The following is a description of a gene set: studied in species Mus musculus Any process that decreases the rate, frequency or extent of fertilization. Fertilization is the union of gametes of opposite sexes during the process of sexual reproduction to form a zygote. It involves the fusion of the gametic nuclei (karyogamy) and cytoplasm (plasmogamy). Mouse Gene Set: GOBP_NEGATIVE_REGULATION_OF_FERTILIZATION, and this is the list of marker genes: Adam24, Zp2, Nlrp5 (NLR family, pyrin domain containing 5), Zp1, Tpst2, Myh9, Plat, Astl